The following is a description of a gene set: Strand-asynchronous mitochondrial DNA replication species: Mus musculus Mouse Gene Set: REACTOME_STRAND_ASYNCHRONOUS_MITOCHONDRIAL_DNA_REPLICATION, and this is the list of marker genes: Twnk, Polg, Ssbp1, Polg2, Polrmt